Given this list of marker genes Ltc4s, here is a description of the gene set: studied in species Mus musculus electronically inferred by orthology from the curated human pathway This event has been computationally inferred from an event that has been demonstrated in another species.<p>The inference is based on the homology mapping from PANTHER. Briefly, reactions for which all involved PhysicalEntities (in input, output and catalyst) have a mapped orthologue/paralogue (for complexes at least 75% of components must have a mapping) are inferred to the other species. part of: Biosynthesis of DHA-derived sulfido conjugates Reactome Pathway: Biosynthesis of maresin conjugates in tissue regeneration (MCTR)